Given this list of marker genes GRAMD1B, DCX, GMCL1, ERBB4, SYTL5, PIGH, CHTF8, PPP1R12A (protein phosphatase 1 regulatory subunit 12A), SERPINA11, MTCL2, ADGRL3, CMTM6, AKAP13, ABCB10, SMIM14, KDM2A, ZBTB7C, CADM1, MED9, RABGAP1, ARHGDIB, FAT4, SOS2, CRADD, LUZP1, ARHGEF12, NT5DC3, ZBTB37, SLC12A6, GREM1, RSBN1L, KLF7, LIMD1, ETS1, CNOT6, ADNP, CNOT2, SP4, AIMP2, KCNJ2, YPEL1, CST3, SYT17, ZNF618, GALNT14, NUFIP2, PEA15, FHDC1, ITGA5, CD247, STARD7, TTC39C, MMP1, AP4B1, ARMC9, AKR1C3, IFT88, INO80D, P2RY10, GNAZ, NIPAL4, CAMK1G (calcium/calmodulin dependent protein kinase IG), VWA5B1, BMAL2, CLOCK, TMEM230, ASB8, URM1, ZYG11B, SETDB2, ARB2A, PKM, GTPBP2, here is a description of the gene set: Genes predicted to be targets of miRBase v22 microRNA hsa-miR-3176 in miRDB v6.0 with MirTarget v4 prediction scores > 80 (high confidence targets). from publication Chen Y, Wang X (PMID 31504780) Human Gene Set: MIR3176 species: Homo sapiens